Given this list of marker genes RPS6KA5, WWOX, CALR, TNFRSF9, SEMA7A, PDLIM7, MUC4, CFD, GIPR, SRSF7, FBLN1, TOP2A, MARF1, PPIB, OFD1, ADK, PRG2, SEMA6C, ITGB1, GPC4 (NCBI Gene Id 2239), IFNAR1, SMPD1, ADCYAP1, UTP3, SOX12, PEX14, SREBF2, MSMB, FAM168B, HMGCS2, ARPP19 (cAMP regulated phosphoprotein 19), ZSCAN12, LAPTM4B, MAST4 (microtubule associated serine/threonine kinase family member 4), KRAS, KLK13, S100A9, HMGN2, BCL7A, NUP160, DAPK2, TDG, PRKD2, GPAA1, ZNF212, ZMYM2, PSMD3, B4GALT1, SPAG7, CAPZA1, TIMP3, TEX30, TCIRG1, ANKRD40, PSCA (NCBI Gene Id 90297), IRAK3, SECTM1, LTBP4, UBE4B, TESK1, SOX9, ZNF384, MCM5, MED12, SP140, PLCG2, RYR2, FADS1, ACRV1 (acrosomal vesicle protein 1), HNRNPL, SRGN, OTUB1, MINDY2, FCMR, ESRRG, SHB, PTOV1-AS1, PRELID3A, SPECC1L, MYL6B, BTN3A1, ST20, FOXK2, EIF4A3, SNX17, LAMP1, FARP1, ERBB3, C6orf47, FAT2, COG4, SSNA1, EFNA2, ZDHHC18, WBP4, CCSER2, OPCML, ADH5 (alcohol dehydrogenase 5 (class III), chi polypeptide), PTPRA, CHMP1A, SC5D, IL16, DPM2, SDC4, ATP5MC3, FOXJ2, ABCF3, MED21, RPL18, PAK1, STK19, GBE1, RABIF, PCF11, GLT8D1, UGP2 (UDP-glucose pyrophosphorylase 2), CLK1, SLC7A5, POLR2J, ASF1A, PRKCA, RBCK1, MX2, TFIP11, POU6F2, VGLL4, POLRMT, MTX1, KRT13, ASAH1, ATP2B2, CHUK, PISD, SSB, ATP6AP1, KLK6, CEBPA, USPL1, TCTA, SCFD1, CSK, SEZ6L, KDM5C, RIMBP2, PTPRU, COX6A1, SMURF2, LY6E, ARPC1A, TGFB1I1, THOC2, UGT2B7, CSNK1E, ANP32B, ADSS2, ENSA, MYOG, PFKFB1, BCKDHA, ADAMTS3, RRN3P1, WHAMM, ICE1, ZFHX3, DDX52, PDE10A, PLD3, ITGA6, FGFR2, SPN, BTG2, FSCN1, PTP4A3, MPHOSPH8, SORBS3, LPL, ORC4, DYRK4, HMGB1, HYAL2, GLS, CRIPTO, KRTAP26-1, MYO1F, PAF1, IMP4, INPPL1, SUCO, ATP5PB, ACIN1, SP100, PUF60, DDX28, POP4, HLA-E, NARS1, C3AR1 (complement C3a receptor 1), PGD, PCGF1 (NCBI Gene Id 84759), RBM14, here is a description of the gene set: Monocyte-derived dendritic cells (DC) and macrophages (MΦ) generated in vitro from the same individual blood donors were exposed to five different pathogens, and gene expression profiles were assessed by microarray analysis. Responses to Mycobacterium tuberculosis and to phylogenetically distinct protozoan (Leishmania major, L. donovani, Toxoplasma gondii) and helminth (Brugia malayi) parasites were examined, each of which produces chronic infections in humans yet vary considerably in the nature of the immune responses they trigger. species: Homo sapiens from publication Chaussabel D, Semnani RT, McDowell MA, Sacks D, Sher A, Nutman TB (PMID 12663451) Human Gene Set: GSE360_CTRL_VS_B_MALAYI_LOW_DOSE_MAC_UP Genes up-regulated in comparison of macrophages versus macrophages exposed to B. malayi (5 worms/well).